Given this list of marker genes Furin, Adora1, Npy, Shh, Pcsk6, Hap1, here is a description of the gene set: The appearance of a neurotrophin due to biosynthesis or secretion by cells in a neuron's target field, resulting in an increase in its intracellular or extracellular levels. A neurotrophin is any of a family of growth factors that prevent apoptosis in neurons and promote nerve growth. studied in species Mus musculus Mouse Gene Set: GOBP_NEUROTROPHIN_PRODUCTION